Given this list of marker genes Spint2, Prl2c2, Hrg, Crk, Acta2, Muc2, Sap30l, Ccr7, Angptl3, Cxcl12, Gria1, C3ar1, S1pr1, Cited2, Arrdc3, Prkd1, St3gal4, Plcg1, Rin3, Defb1, Pik3r2, Sema3g, Tmsb15b1, Plet1, Idh2, Lbp, Pfn1, Ptprk (NCBI Gene Id 19272), Sp1, Cd81, Coro1a, Fgf1, Fbxo31, Jcad, Pitx2, Tnfsf18, Lef1, Insr, Dusp10, Twist2, Itgb1, Serpinf1, Hdac7, Cd200r1, Pak1, Hnf4a, P2ry6, Vegfa, Ccr1l1 (C-C motif chemokine receptor 1 like 1), Ptprt, Stk10, Mapk3, Tgfb2 (NCBI Gene Id 98738), Ing2, Acvr1c, F7, Abcc8, Gpi1, Rap2b, Fgf4 (fibroblast growth factor 4), Egfr, Lmo4, Atoh8, Cln3, Lyve1, Sorl1, Amot, Sst, Prcp, Gli1, Fut7, Mpp1, Fer, Rnf41, Fgf10, Dapk2, Itga5 (NCBI Gene Id 16402), Pak3, Itgav, Sox14, Spns2, Cdkn1b, Nos3, Snca, Egr1, Crkl (v-crk avian sarcoma virus CT10 oncogene homolog-like), F2r, Macir, Rcc2, Sema3c, Fut9, Il16, Trpv4, Timp1, Sema4a, Mmp9, Fgf5, Mir218-1, Ulk4, Serpine1, Tnn, Cdh11, Drd1, Wnk1, Ccl19-ps5, Ogt, Reck, Src, Cxcl17, Scg2, Ppbp, Cldn3, Wnt5b, BC037156, Lamb1, Cxcl10, Anxa3, Gcnt2, Ccar1, Lrrc15, Ccl9, Elp5, Flrt2, Igf1r, Arhgdib, Sema6d, Dock4, Xbp1 (X-box binding protein 1), Mctp1, Ccl25, Ackr3, Zmynd8 (zinc finger, MYND-type containing 8), Abr, Vim, Cd200, Efemp1, Gpnmb, Usp14, Tbxa2r, Ctnna1, Mcu, Nodal, Trip6, Cttn, Pld1, Gata2, Mmp7, Stk4, Ldlrad4, Carmil2, S100a11-ps, Dock7, Zfp609, Mmp3, Hmox1, F3, Chrm1, Med23, Epha4, Ripk3, Zfp640, Sdc4, Cyp19a1, Plcg2, Tfap2a, Slc8a1, Cdh1, Cfap45, Fubp1, Gcnt1, Ccr6, Tradd, Ephb2, Perp, Abl1, Ifnb1, Ccdc25, Stat5a, Ccr1, Ascl2, Srgap2, Pgf, Gnrh1, Ttll6, Kif26a, Il23a, Itga2b, Akt1, Cyp1b1 (cytochrome P450, family 1, subfamily b, polypeptide 1), Adam10, Mkks, Prr5, Jup, Map3k1, Cdh5, Ager, Mapk15, Il24, Fuz, Tcaf1, Hbegf, Kif9, Gtpbp4, Lgr6, Rnf7, Rapgef3, Rbbp7, Atm, Rdx, Cd69, Rhoj, Hgf, Ccbe1, Ago2, Cxcl14, Card10, Robo4, Camk1d, Ifitm1, Uts2, Sparc, Adtrp, Vcl, Nexn, Adgra2, Srgap3, Ptprm, Col1a1, Tirap, Il1r1, Tnfaip6, Emp2, Nox1, Stat5b, Prkd2, Ryk, Fga, Ccl4, Rbbp4, Tnr, Nipbl, Spata13, Lrch1, Fezf2, Gpr183, Elp3, Ghrl, Smarca4, Ccl3, Ctsh, Clasp2, Dab2ip, Sfrp1, Slit1, Cort, Gdf2, Pik3r1, Zeb2, Mef2c, Stard13, Vegfd, Fbln1, Scai (NCBI Gene Id 99056), Twist1, Fgf8, Defb37, Phldb2, Fgf16, Gper1, Tmem102, Casr, Magi2, Diaph1, Arsb, Pax6, Cep43, Angpt4, Dlg5 (discs large MAGUK scaffold protein 5), Postn, Arhgef39, Csf2, Cpeb1, Lama2, Sele, Fadd (NCBI Gene Id 14082), Gcsam, Plxnc1, Dusp22, Ripor2, Dock5, Tnfsf14, Eppin, Sinhcaf, Fermt2, Dock10, Emilin1, Mmp14, Wnt4, Cxcl13, Wnt11, Itgb1bp1, Trib1, Tbccd1, Cd47, Clasp1, Sema3b, Fgr, Plxna2, Tmsb15b2, Eppk1 (NCBI Gene Id 223651), Tert, Cldn13, Hspb1, Wdr62, Kank1, Atp8a1, Ptprr, Shtn1, Limch1, Rap2a, Aire, Cxcr4, Ccn4, Snai1, Ccl8, Mink1, Pkn2, Ccl12, Mtus1, Adora1, Mst1, Gm266, Clec7a, Elane, Has2, Tacr1, Flt4, Hdac2, Fgf2, Sdcbp, Duox2, Nbl1, Nox4, Bbs2, Tsc2, Ccl24, Arid4b, Sema3e, Kif21a, Bmper, Glul, Nsmf, Trem1, Nav3, Itga4, Gna13, Dock1, Dapk3, Tie1, Pycard, Actr3, Osbpl8, Fbxo5, Ccl19-ps1, Ythdf3, Dpep1, Myo5a, Lgmn, Maz, Slk, Ccr4, Krt16, Emilin2, P2ry2, Cadm4, Jam3, Dll4, Ppm1f, Lama3, Bag4, Lrrk2, Cldn19, Acp5, Cdk5, Plaa, Tacr2, Pld2, Arpin, Acan, Gpr173, Il34, Mcam, Camk2b, Rin2, Ptprj, Carmil1, Tmsb15a, Ptgs2, Scrt1, Sfrp2, Bst1, Wfdc6a, Gdf15, Tgfbr1, Ccl26, Zfp580, Dsg3, Myh9, Camk2d, Tppp2, Furin (NCBI Gene Id 78149), Insl3, Mmp2, Rock1, Hras, Plpp3, Defb25, Abhd6, Met, Tafa5, Cldn1, Kif14, Dcn, Adam7, Plvap, Mstn, Tmsb4x, Onecut2, Fgf7 (NCBI Gene Id 14178), Efnb2, Prex1, Gna12, Spn, Actg1, Arpc2, Cass4, Ptk2, Zp3, Dnai3, Adamts1, Ccl19-ps6, Jag1, Nisch, Bex6, Sema7a, Il33, Gstp2, Rufy3, Ccl6, Mir218-2, Bmp2, Ninj1, Cd74, Il6st, Sin3a, Tnfsf4, Appl1, Epb41l4b, Fam110c, Foxo3, Ccl19-ps4, Bbs4, Mmp12, Mysm1, Fpr-rs6, Bdkrb1, Msn, Tmeff2, Plxnb3, Pdgfra, Ajuba, Atp5f1a, Plp1 (NCBI Gene Id 18823), Igsf10 (NCBI Gene Id 99612), Map3k7, Irs2, Reln (NCBI Gene Id 19699), Erdr1, Dock8, S2bpcox16, Mapk1, Cavin1, Nckap1l, Sphk1, Adgrb1, Ccl11, Gnai2, Iqcf1, Pdgfd, Dag1, Mta2, Rarres2, Ptger3, Tac2, Rgn, Tlr4, Tet1, Myc, Ddrgk1 (NCBI Gene Id 98926), Arhgdia, Mia3, Creb3, Tek, Cav1, Vrk1, Jam2, Rhob, Tmem196, Amotl1, Ptprg, Bcr, Pdpk1, Nherf1, Tjp1 (NCBI Gene Id 381892), Ripor1, Adra2a, Il1a, Ythdf1, Chrd, Ptprc, Angpt2, Adipor2, Ano6, Rreb1, Smad3, Was, Dysf, Suds3, C5ar2, Fam83h, Sema5a, Rras2 (related RAS viral (r-ras) oncogene 2), Cd63, Tlr2, Spag9, Prkce, Slurp1, Myoc (myocilin), C1qbp, Iqgap1, Catsper1, Slamf8, Icam1, Capn1 (calpain 1), Scrt2, Foxf1, Dab2, Rtn4, Il1b, Lcn2, Mylk, Bmp10, Grin1, Tnf, Tacr3, S100a11, Mospd2, Pfn2, Alox12, Adarb1, Amotl2, Slamf1, Ccl21f, Hdac5, Pde4d, Dach1 (dachshund family transcription factor 1), Igf2, Camsap3, Ntf3, Bmp4, Vil1, Hoxa7, Tpm1, Spi1, Glipr2, Fat1, Ghsr, Spry2, Egfl7, Onecut1, Fpr-rs3, Bves (blood vessel epicardial substance), Edn1, Ccl20, Thbs1, Edn3 (endothelin 3), Fbxw7, Synj2bp, Grn, Ptpn1, Pdcd10, Dbn1, Ace, Ldb1, Ror2 (receptor tyrosine kinase-like orphan receptor 2), Ccl21e, Stat3, Ptprz1, Pik3cb, Insm1, Lamc2, Gja1, Svbp, Smurf2, Sema5b, Spred1, Gpr18, Dmtn, Fbxo7, Ptger4, Flt1, Itgax, Appl2, Pparg, Drd4, Fam89b, Ilk, Trim32, Ntng1, Irgc, Myocd (NCBI Gene Id 214384), Fermt3, Lpar1, Syne2, Ctnna2, Myadm, Thbs4, Sod2, Abhd2, Prr5l, Plekhg3, Itgb3, Ceacam1, Itga3, Tbr1, Bcl6, Prkx, Meox2, Stap1, Sirt1, Arhgap4, Sin3b, Tgfbr3, Klrk1 (NCBI Gene Id 27007), Madcam1, Pin1rt1, Fgfr1, Plg, Miip, Rnase10, Ttbk2 (tau tubulin kinase 2), Cx3cl1, Tshr, Ing1, Calr, Smoc2, Tbx5, Fgf21, Srgap1, Hdac6, Cd300a, Ddr2, Ecm1, Fgf6, Pla2g7, Rgcc, Lama5, Rigi, Cxcr3, Fgf17, Arhgef2, Wnt5a, Sucnr1, Evl, Nod2, Fgf23, Gstp1, Tmsb10, Sema4f, Rhoa, Aif1, Pdgfrb (platelet derived growth factor receptor, beta polypeptide), Ldb2, Angpt1, Vegfc, Mycbp2, Rnase9, Ccl21a (NCBI Gene Id 18829), P4hb, Abi3, Kit, Klf4, Ccl7, Mtor, Sema4g, Phactr1, Ntrk3, Hyal2, Csf1, Wdr44, Pkn1, Anxa1, Sap30 (sin3 associated polypeptide), Phlda2, Igsf8, Nus1, Tbc1d24, Srf, Fgf18, Kitl, Plau, Chst2, Tex101, P2rx4 (NCBI Gene Id 52272), Meak7, Prl7d1, Slc8b1, Selenok, Tacstd2, Map2k2, Nog, Slc26a5, F2rl1, Vtn, Frmd5, Osgin1, Adamts9, Plxna3, Rack1, Bex4, Gas2l2, Cdc42, Trf, Il1rn, Wfdc6b, Fes, Sox9, Ccl5, Chrm4, Fut1, Bmerb1, Pik3cd, Aldoa, Plxna1 (plexin A1), Adgrg1, Rock2, Lrp1, Rras, Sulf1, Akt3, Wnt7a, Tnc, Hif1a, Igf1, Cpne3, Dlc1, Fam107a, Srpx2, Stmn1, Epcam, Srcin1, Ptpn22, Pkp2, Fgf9, Dnaja4, Retn, Rhoc, Epha2, Pik3c2a, Il12a, Fbn2, Vsir (NCBI Gene Id 74048), Cldn4, Sema4d, Nr4a3, Sema4b, Arhgap5, Mmrn2, Lyn, Arid2, Marveld3, Dpp4, Map2k5, Mif, Il27ra, Apc, Htr1d, Lama4, Iqsec1, Clic4, Mecp2, Pdcd6, Apoe (apolipoprotein E), Cxcr2 (C-X-C motif chemokine receptor 2), Brms1, Ptpru, Pcsk5, Arhgap32, Or4m1, Apela, Adam8, Ndrg4, Nrg3, Mdm2, Tnfrsf18, Kdr, Wdpcp, Grem1, Gas6, Cib1, Agrn, Chst4, Drd5, Atp1b2 (ATPase, Na+/K+ transporting, beta 2 polypeptide), Numb, Tiam1, Jak2, Sema3d, Wnt3a, Pin1, Rac1, Gfus, Kif20b, Mmp1a, Ifng, Robo3, Arf6, Sec1, Ptafr, Ccn3, Lmna, Plxna4, Sema6a, Dicer1, Erbb4, Stx3, Cldn5 (NCBI Gene Id 21920), Ptp4a1, Trp53, Ppargc1a, Tpbg, Rap2c, Rac3, Fignl2, Enpp2, Hace1, Mien1, Pgr, Hc, Ssx2ip (SSX family member 2 interacting protein), Stc1, Apod, Adam17, Eng, Map2k3, Podn, Patz1, Akirin1, Ednra, Cfap206, Ap1ar (NCBI Gene Id 99472), Mcc, Daam2, Stk39, Mgat5, Ntng2, Padi2, Spinkl, Gp1ba, Dscam, Egf, Adam15, Coro1c, Akap12, Kiss1r (KISS1 receptor), Atoh7, Ret, Smim22, Macf1, Myo1f, Rnf20, Duox1, Ccr2, Cx3cr1, Robo2, Unc5d, Trem2, Gadd45a, Atp5f1b, Stk26, Ccl21b, Prkg1, Abcc1, Rac2, Vegfb, Adipor1, Ccl1, Mgat3, Cd99l2, Tac4, Cnn2 (calponin 2), Hspa5, Sdc3, Emc10, Pten, Ptpn2, Itga2, Aoc3, Pawr, Nedd9, Myo1c, Rps6kb1 (NCBI Gene Id 72508), Zc3h12a, Sap130, Prkca, Fgf20, Fut4, Csf1r, Apoh, Stx4a, Lrig2, Rabgef1, Lgals3, Zswim6, Nrp1, Hdac1, Wnt3, Tmigd3, Foxp1, Map2k1, Nkx6-1, Nexmif (neurite extension and migration factor), Nck1, Slit2, Ube2i, Ptn, Foxo4, P2ry12, Casp8, Epha3, Nr2f2, Plxnb1, Mapk8, Cd151 (NCBI Gene Id 12476), Pdgfc, Tgfb1, Cygb, Hmgb1, Krt5 (keratin 5), Ccl2, Podxl, Camk2a, Ets1, Plxnd1, Arhgap18, Zfp703, Arid4a, Adora2b, Rab11a, Tff2, Swap70, Mapre2, App, Edn2, Anxa5, Nkx2-1, Ppp3ca, Snai2, Dusp3, Xcl1, Gata3 (GATA binding protein 3), Sema4c, Nrg1 (neuregulin 1), Myd88 (NCBI Gene Id 17874), Adipoq, Cldn7, Clxn, Ccl19, Krit1, Notch1, Col3a1, Abl2, Shh, Agt, Dpysl3, Stk24, Ada, Elp6, St6gal1, Rapgef4, Sema3f, Dnm1l, Thy1, Cers2, Bmpr2, Cemip, Rapgef2, Inpp5f, Actn4, Gab1, Cfap20 (cilia and flagella associated protein 20), Itga6, Bcl2, Nfe2l2, Fgf3, S100a14, Il18, Smo, Grb7, Cyrib, Kif2a, Unc5c, Mmp10, Epha1, Ccl21d, Prag1, Fn1, Atp2b4, Mdk, Akt2 (thymoma viral proto-oncogene 2), Sp100, Wasl (NCBI Gene Id 73178), Bcar1, Atp7a, Fpr-rs4, Ccl28, Sell, Artn, Epb41l5, Tnfrsf14, Gsx2, Fgf15, Smpd3 (NCBI Gene Id 80691), Hdac4, Fpr-rs7, Fpr2, Capn7, Phpt1, Rhod, Tgfbr2, Igfbp5, Park7, Prdm14, Ezh2, Hdac9, Sema6c, Pdgfa, Gla, Cripto, Bsg, Gab2, Cfl1 (NCBI Gene Id 12631), Bbs1, Cul5, Vps35, Ssh1, Tac1, Cbll1, Plk2, Peak1, Foxc2, Ngfr, Plcb1, Selp, Syde1, Drd3, Pdpn, Brms1l, Flna, Ppard, Ptgr1, Rffl, Has1, Trp53inp1, Rab25, Vash1, Fgfbp1, Usp17le, Igfbp3, Map4k4, Pik3cg, Mmp28, Sun2, Coro1b, Efna1, Cd40, Adora3, Bmp7, Adgrg3, Irs1, Bst2, Ccn1, Ccr5, Ntn1, Scrib (NCBI Gene Id 54559), Gsk3b, Robo1, Sash1, Gpsm3, Drd2, Mmrn1, Ptk2b, Acvr1, Fzd4, Mapk8ip3, Gpr15lg, Fas, Cd9, S1pr2, Prox1, Tmem201, Il4, Bmpr1a, Pecam1, Lama1, Synpo2, Aqp1, Fgf22, Cxcl16, Ccl22, Gpld1, Nf1, Jun, Cd274, Ppp2r3a, C5ar1, Pou4f2, Acvrl1, Fermt1, Nr2e1, Cmklr1, Megf8, Tubb2b, Hyal1, Lgals9, Duoxa2, Oxsr1, Kiss1 (KiSS-1 metastasis-suppressor), Cfap69, Dusp1, Plxnb2, Nova2, Tmigd1, Acvr1b, Sh3rf2, Sema6b (NCBI Gene Id 20359), Apex1 (apurinic/apyrimidinic endonuclease 1), Braf, Col18a1, Cdh13, Afdn (afadin, adherens junction formation factor), Ccl19-ps3, Ptpn23, Ccdc125, Pip5kl1, Mitf, Map3k3, Csnk2b, Bcas3, Pdgfb, Adam9, Ssh2, Sh3bp1, Sema3a, here is a description of the gene set: Mouse Gene Set: GOBP_REGULATION_OF_LOCOMOTION studied in species Mus musculus Any process that modulates the frequency, rate or extent of locomotion of a cell or organism.